Given this list of marker genes POR, SRD5A1, SCX, EFNA5, EDN1, GCLC, GATA1, GHSR, INHBA, FSHR, NOTCH1, EPHA8, GCLM, SRD5A2, EDNRA, TGFBR3 (transforming growth factor beta receptor 3), here is a description of the gene set: Any process that results in a change in state or activity of a cell or an organism (in terms of movement, secretion, enzyme production, gene expression, etc.) as a result of a follicle-stimulating hormone stimulus. Human Gene Set: GOBP_RESPONSE_TO_FOLLICLE_STIMULATING_HORMONE species: Homo sapiens